Given this list of marker genes ZNF493, VDR, ZNF461, SETD1A, ZNF544, RAD51D, TFDP1, MYB, ZNF214, ELL, ZNF350, CHD4, RPS27A, SOX2, SUPT16H, H2AC14, LSM10, PTEN, MBD3, TFDP2, ZNF790, IWS1, THRB, PF4, RAD9A, ZNF671, JUN, MIR132, SIRT1, PRKAB2, CHEK1, ZIM3, POLR2I, RUNX3 (RUNX family transcription factor 3), ZNF79, BRD7, ZNF28, ZNF735, MAMLD1, TRIM63, ZNF33A, PHC1, ARID3A, PSMB4, USP2, ANAPC2, TBL1X, OPRK1, ZNF224, CNOT6, ZNF611, NR5A2, CBFB, PIP4K2C, G6PD, JUNB, SNAPC5, ZNF26, CREB1, H2BC14, ZNF200, H2BC15, ZNF627, MIR302B, GLI3, INTS10, MT-CO3, EHMT1, UBA52, BBC3, ZNF571, IHH, NR4A3, AGO4, LAMTOR5, PSMC5, GPX2, KMT2A, PHC2, H3C1 (H3 clustered histone 1, NCBI Gene Id 8350), SMURF1, H2BC11, SNRPD3, SSRP1, PRMT5, TFAP2B, NOTCH4, NR6A1, ZNF454, NOC2L, H2BC5, ZFP69B, MRE11, ZNF730, GTF2H5, MED8, ZNF610, ZNF684, COX7A1 (cytochrome c oxidase subunit 7A1), SOX9, ZNF253, RORB, H3C15 (H3 clustered histone 15), PHAX, PCK1, GATA3, ICE1, CSTF3, PPP2CA, ELL2, ZNF75D, GPS2, ZNF737, ZNF761, POU2F2, NR1D2, ZNF432, RRAGC, YWHAH, MED23, ELL3, ZNF551, MYBL2, ZNF519, SMAD6, SESN2, SMAD1, TEAD2, WDR5, CSF1R, ARID2, ZIM2, CCND3, NABP1, ZNF221, ZNF697, ZNF222 (NCBI Gene Id 7673), ZSCAN32, CR1, H2BC1, NCOR1, SOCS4, PML, NR2F6, ZNF470, PLK3, ZNF74, CTLA4, CSNK2A2, MECP2, SKIC8, EXO1, COX5B, LGALS3, RPRD1A (regulation of nuclear pre-mRNA domain containing 1A), WWOX, PCGF5, CDK2, ABL1, ZNF215, RARB, MLLT3, PSMB7, SUPT5H, H2AJ, SMAD4, TP53BP2, ARNT (aryl hydrocarbon receptor nuclear translocator), TNFRSF10C, MED26, MAF, ATAD2, HDAC2, TFAP2D, ZNF34, ZNF705G, CNOT10, ZNF620, MSTN (myostatin), H2BC12, ZNF506, ZNF441, ZKSCAN1, ZFP90, RBFOX3, CGA, ZNF705D, FANCI, NR3C1, ZNF772, SMARCA2, ZC3H8, MED4, HES1, TNRC6B, ZNF679, ZNF584, ZNF699, BMI1, CDK5R1, NEDD4L, ZNF124, TP53I3, PSMD11 (NCBI Gene Id 5717), PRKAB1, RFC5, TAF13, NPY (NCBI Gene Id 4852), PRKCQ, GSK3B, BTG1, YWHAG, ZNF354B, ZNF320, RHEB, RRM2, SMAD7, ZKSCAN8, RABGGTA, UBE2D1 (ubiquitin conjugating enzyme E2 D1), ZNF615, PMS2, DEK, PPP1R13L, INTS3, ANAPC15, ZNF445, MED24, NR1D1, POLR2D, INTS8, PSMB1, PRKACA, INTS2, SPP1, HUS1, APAF1, POLR2F, CAMK2A, SNW1, YEATS4, PSMC2 (NCBI Gene Id 5701), ZNF331, YWHAZ, HIGD1C (HIG1 hypoxia inducible domain family member 1C), TAF7, FIP1L1, FZR1, RPRD2, BIRC5, SKIL (SKI like proto-oncogene), ZNF135, LDB1, KMT2C, CDK8, ANAPC10, TP63, CNOT8 (NCBI Gene Id 9337), ZNF19, AR, SMARCC1, CNOT6L, NR3C2, JMY, DYRK2, TAF10, ZNF724, CNOT7, ZNF75CP, ITGA5, RBPJ, SNRPG, L3MBTL2, BDNF, SKI, SMYD2, ZNF517, ZIK1, PPP1R13B, PPARD, TWIST2, POLR2A, FOXO4, CTNNB1, TSC2, ZNF263, MDM4 (NCBI Gene Id 4194), USP9X, DNA2, TNRC6A (trinucleotide repeat containing adaptor 6A), LAMTOR1, ARNT2, IGFBP1, TNFRSF18, ZNF577, TAF15, MED25, TAF4, SUZ12, ZNF41, CCND2, ELF1, RET, SMARCE1, SOD2, GPI, ZFP28, CITED2, BMP2, TIGAR, ZNF479, RNMT, CBX3, ZNF703, MYC, PCGF6, LAMTOR4, HTT, IL2RA, SFN, FOXG1, GTF2B, RBL2, ESRRB, PSMD14, OPRM1, ZFP69, ZNF394, ZNF785 (NCBI Gene Id 146540), MIR378, CCNT1, RNF34, BANP, INTS14, ELOA2, ESRRA, CYCS, ZNF140, SIN3B, MIR675, ZNF714, RABGGTB, CCNH, UXT, PCGF2 (polycomb group ring finger 2), ZNF840P (NCBI Gene Id 140896), PRKAA2, FASLG, H2AC4, PRDX1, CDKN2B, ZNF92, PSMB5, ING5, ZNF606, RSPO3, ZNF791, TAF4B, MEAF6, PIP4P1, MDM2, ATP1B4, GRIN2A, GAMT, ZFP37 (ZFP37 zinc finger protein), SP1, PSMA7, ZNF589, SMARCC2, COL1A2, PSMD7, ZNF426, TOPBP1, TNFRSF10A, MAPK11, NCOR2, THBS1, ZNF713, BNIP3L, RARG, ZNF732, miR-224, INTS5, RPA3, NABP2, RUNX2, IL6, LMO1, TP53RK, TAF12, PSMB6, ZNF776, CSNK2A1, ELOC, ZNF416, TXN, ZFP30, TNKS1BP1, TJP1, INTS1, CDC7, DLL1 (NCBI Gene Id 28514), PSMA6, ZNF681, ZNF429, NFE2 (NCBI Gene Id 4778), NFKB1, ARID1A, TTC5, ZNF860, ZNF431, BAX, NELFE, ZNF721, GTF2E2, MAML3, GTF2A2, MIR24-1, CNOT3, NLRC4, ZNF773, STK11, KLF4, MIR18A, KRABD5, RPA2, ZNF664, CBX8, ZNF559, CDK6, EHMT2, ZNF740 (NCBI Gene Id 283337), PRDX2, ZNF197, ZNF471, SMARCA4, PRKAG2, ANAPC4 (anaphase promoting complex subunit 4), CCNB1, UBE2I, SGK1 (serum/glucocorticoid regulated kinase 1, NCBI Gene Id 6446), PGR, ZNF169, TAF1L, RRAGA, CDKN1A, TCEA1, ZNF317, ZNF266 (NCBI Gene Id 10781), BRPF1, NELFCD, TRPC3, SLC2A3, CDK13, DAXX, ZNF662, SMARCD3, ZNF677, NCBP1, H2AZ2, CCND1, ZNF225, AIFM2, CCNG2, ZNF17, PRMT1, RMI1, PPP2R1B, RORA, ANAPC5, TAF9, ZNF563 (NCBI Gene Id 147837), RARA, ING2, ZFPM1 (NCBI Gene Id 161884), CDC26, NOTCH1, RNU11, RNF2, ATR, ZNF333, BRCA1 (BRCA1 DNA repair associated), BMAL1 (basic helix-loop-helix ARNT like 1), CPSF1 (cleavage and polyadenylation specific factor 1), RB1, GATAD2A, TP73, MED7, ZNF446, SPI1, ZNF767P, PIP4K2B, PSMA3, ZNF480, ZNF433, ZNF311, TEAD3, ZNF670, LAMTOR2, DDIT4, ZNF442, NFYB, POLR2B, UBE2C, HEY2, ZNF43, MAPK1, ZNF667, ZNF558, ZKSCAN5, RNU4-1, ZNF675, BTG2, KRABD4, ZNF750, GTF2H1, SNAPC4 (small nuclear RNA activating complex polypeptide 4), MLH1, NOP2, DLX6, H2AC20, ZNF692, AXIN1, ZNF154, ZKSCAN4, LEO1, NR1H4, SMARCB1, KDM5B, SCO2, ACTL6B, TEAD1, ZNF223, PRKAG1, EED, POLR2L, ZNF595, HIPK1, CASP10, COX8A, ZNF136, ZNF586, CASP6, PSMA5, ZNF141, CPSF4, NPM1, AFF4, CCNE1, TP53, GAD1, ZNF562, GADD45A, H4C1, POLR2J, FOXP3, ZNF343, RXRB, ZNF705A, COX6B2, EAF2, TCF12, PTPN1, ZNF37A, CBX5, INTS4, KCNIP3, COX7B, SNAPC3, CITED1, MSH2, DLX5, H2BC17, ATXN3, ZNF561, ZNF213, ZNF668, NR2E1, GTF2F2, ZNF774, RBBP5, NELFB, DPY30, ZNF738, ZNF599, CAV1, NR5A1, MIR137, E2F1, IRAK1, RBFOX1, POMC, FOXO1, SLBP, ZNF689, KCTD15, ZNF804B, ITGA4, CTSL (cathepsin L), RYBP, PVALB, PPP2CB, H2AB1, NCBP2, PPARA, RPTOR, DDB2, ZNF500, RNU1-1, CSTF1, CCNE2, CDK12, STEAP3, ZNF565, RICTOR, HDAC1, MAML2, ZNF700, MED17, RNU4ATAC, NFYA, ZNF585B, RNU5A-1, HNF4A, ZNF180, RFC3, MGA, ZNF676, PABPN1, H2AC7, H2BC4, CPSF2, ZNF75A, AKT3 (NCBI Gene Id 26068), ZNF514, ITCH, PITX2, ZNF658B, ZNF138, ANAPC11, SERPINE1, RGCC, NR0B2, ZNF100, GATA2, POLR2C, ZNF324, ZNF23, PARP1, ZNF195, BID, TAF9B, PSMC6, SERPINB13, PSMA4, ZNF189, BRIP1, MTA2 (NCBI Gene Id 9219), TGIF1 (TGFB induced factor homeobox 1), INTS9, BCL2L14, PRMT6, ZNF302 (zinc finger protein 302), RXRG, ZNF554, ARID1B, TAF2, RAD9B, TAF5 (NCBI Gene Id 6877), ZNF688, PSMD8, ZNF212, TAF6, ZNF701, KRABD3, BRPF3, MYL9, GP1BA, GCK, ZNF546, VENTX, MED31, CCN2, ZNF227, ZNF248, KMT2D, UCMA, COL1A1, MAML1, MIR26A1, NR2F1, SUPT6H, COX4I2, SYT10, YY1, ZNF552, CDC27, CPSF7, ZNF264, BLK, NR2C2AP, H2BC26, PRDX5, MAPKAPK5, IL2, SIN3A, H2AC6 (H2A clustered histone 6), CSNK2B, HDAC7, TAL1, AGO3, YWHAQ, ZNF286A, CPAP, NR2C2, RBBP4, HAND2, ZFP2, ZNF418 (NCBI Gene Id 731194, zinc finger protein 418), KAT6A, THRA, ZNF573, G6PC1, WRN, SMAD3, FURIN, XPO1, ZNF33B, MMP13, MAX, KAT2B, CALM1, NAMPT, CAMK2D, ZNF770, ZNF486, SREBF1, LBR, RING1, ANAPC7, MIR26A2, ZNF746, TCF3, UBE2E1, RUNX1, TCF7L1 (NCBI Gene Id 83439), PRKCB, ZNF616, HDAC3, ZFP1, ZNF287, RRAGD, ZNF257, ZNF711, PMAIP1, GATA4, ZNF3, GRIA2, ZNF528, NR1I2, CEBPB (CCAAT enhancer binding protein beta), ZNF304, INTS6, TP53AIP1, MIR106A, TRIM28, CSTF2T, MAPK14, RELA, CARM1, POU4F1, MOBP, CPSF6, TAF3, ZNF226, HIVEP3, E2F8, ZNF101, ZNF496, CNOT1, ZNF99, ZNF282, SMARCD1, CSF2, BCL6, NR1H3, HDAC5, ZNF235, TNRC6C, CSTF2, CNOT9, RAD50, ZNF205, SYMPK, ZFP14, TGFA, ZNF430, TSC1, NELFA, RETN, ACTL6A, ZNF543, ZNF702P (zinc finger protein 702, pseudogene), VEGFA, COX4I1, ZNF12, TCF7L2, LAMTOR3, ZNF337, EPC1, USP7, HEY1, GATAD2B, NOTCH3, LEF1, ZNF555, PSMA1, CDKN2A, RAD17, NUAK1, PSMC4, STAT1, CDK9, RORC, TFAP2E, STUB1 (STIP1 homology and U-box containing protein 1), ZNF691, NR0B1, POLR2H, PPARG, NBN, ZNF211, COX7A2L, E2F4, AKT1 (NCBI Gene Id 207), ZNF300, ITGBL1, MTOR, ZNF77, ZNF256, SRRT, ZNF114, CRH, ZNF621, H2AC18, DDIT3, EAF1, PRELID3A, ZNF669, YAP1, ZNF585A, PRR5, TAF1, PIP4K2A, ZNF727, ZNF704, ZNF613 (zinc finger protein 613), ZNF680, NOTCH2, ZFHX3, FOXO6, MAPK3, TBX5, SRC, SUPT4H1, ZNF485, TP53INP1, ANAPC1, CHM, ZNF415, PSMD6 (proteasome 26S subunit, non-ATPase 6), NUDT21, PRKAG3, ZNF45, SEM1, RXRA, MDC1, ZNF710, ZNF764, ZNF717, CTR9 (CTR9 homolog, Paf1/RNA polymerase II complex component), GEM, OCLN, BGLAP, SESN3, GTF2H4, ZNF706, ZNF556, POLR2G, YES1, ZNF707, TGIF2, ZNF705EP, ZNF660, NFYC, ZNF208, POLR2E, ZNF483, H2BC21, SMAD2, MSX2, HNF4G, ZNF439, ZNF112, CDKN1B, PBRM1, JAG1, HDAC10, MIR215, SESN1, ERCC3, ABCA6, ELF2, ZNF875, GTF2H3, ASH2L, LMO2, E2F5, ZNF777, ZNF557, MED27, CITED4, TEAD4, FAS, SLC38A9, ZNF14, PSMC1 (proteasome 26S subunit, ATPase 1), RFC4, SNAPC1, ZNF570, MNAT1, NRBF2, ATRIP, NR4A2, MIR20A, ZNF726, ZNF658, ZNF20, ZNF230, RNF111 (NCBI Gene Id 54778), CAMK4, ZNF775, SMURF2, PSMD1, TRIM33, POU4F2, ZNF607, SETD9, PSMB2, ZNF354C, GSR, NR2C1 (nuclear receptor subfamily 2 group C member 1), CDC23, ZNF718, ZNF597, RTF1, MLLT1, MED6, ZNF792, ZNF799, RNU12, CTSV, PRELID1, LIFR, HDAC9, IFNG, COX6A2, PPM1D, ZNF133, TFAP2C, ELOB, HSPD1, CCNK, ZNF549, TNFRSF10B, PINK1, ZNF155, ZKSCAN3, ZNF420, HDAC8, MOV10, ZNF569, ZNF492, PLAGL1, NRBP1, PLXNA4, ICE2, CDC25C, PSMD2, YAF2, KMT5A, TRIAP1, ZNF443, ZNF619, FOS, UBB, UBE2D3, PPP2R5C, ZNF678, PHF20, RNU2-1, ANAPC16, RPAP2, ZNF583, CCNA2, ZNF398, ESR2, KAT2A, ZNF665, RRM2B, PIDD1, COX5A, CRADD, MED1, RFFL, ZNF440, H2BC12L, RHNO1, CNOT4, GTF2H2, H2BC3, ZNF550, ZNF709, ZNF157 (zinc finger protein 157), GTF2A1, MIR27A, CAT, PRDM7, ZNF202, HDAC11, ITGAL, RFC2, ZNF596, ZNF2, ZNF749 (NCBI Gene Id 388567), COX7C, CDC16, E2F7, TCF7, ZNF484, DGCR8, SP7, CPSF3, ZNF10, HDAC6, CDC73, MAGED1, CLP1, HIPK2, MED10, ZNF747, EZH2, ZNF839, ZNF382, INTS7, TGFB1, ZNF268, POLR2K, SST, CNOT11, GATA1, AUTS2, TWIST1, PDPK1, ZNF626, INTS13, ZNF716, CBX2, POU2F1, ZNF417, MED16, ZNF529, PPP2R1A, UBC, PAPOLA, ZNF234, ZNF736, RBBP8, PAF1, AKT2, REST, COX7A2, INTS12, FBXO32, ZNF233, ADRM1, AURKA, IL3, IGFBP3, ZNF649, TAF11, PCNA, E2F6, LSM11, TNFRSF10D, ZNF729, NR1I3, SOCS3, TOP3A, PTPN11, COX6C, TXNRD1, GLS2, FANCD2, ZNF143, ELOA, BLM, ZNF793, AURKB, H2AX, PSMD3, MIR24-2, YWHAB, GLS, ZNF324B, TBP, IQSEC3, ZNF468, FKBP5, PSMB3, RPRD1B, ZNF696, TMEM219, ZNF334, ZNF560, ZNF25, KIT (KIT proto-oncogene, receptor tyrosine kinase), RNGTT (RNA guanylyltransferase and 5'-phosphatase), ZNF624, BRD1, WDR33, MAPKAP1, SKP2, H2BC13, MED13, ZNF160, ZNF540, ZNF30, SETD1B, UBE2S, ZNF530, SATB2, CLDN5, GPRIN1, ZNF175, ZNF267, SRF, NFATC2, ZNF641, RBM14, ZNF354A, ZNF436, GRIN2B, ZNF771, RBX1, FANCC, PTPN4, MED15, TFAP2A, SSU72, KAT5, PAX5, ATF2, YWHAE, SNRPB, PIN1, CCNG1, KCTD6, ZNF547, MED20, TBL1XR1, MED14, ITGA2B, PHC3, ZNF425, COX8C, ZNF383, ZNF285, EGFR, ZNF419 (zinc finger protein 419), CNOT2, ZNF567, ZNF18 (zinc finger protein 18), RBBP7, COXFA4, ESRRG, ZNF614, SKP1, RAD51, PRDM1, RAD1, CHEK2, CASP2, BRD2, ERCC2, MED12, SIRT3, CDK1, ZNF726P1, KRAS, MT-CO1, CDK7, ZSCAN25, CAMK2G, ESR1, CUL1, CCNC, COX6A1, ZNF582, CAMK2B, NR2E3, APOE, ZNF347, CBX4, RBL1, GTF2F1, ZNF548, ZNF273, INTS11, CTSK, WWP1, NR1H2, CASP1, CGB3 (chorionic gonadotropin subunit beta 3), ZNF625, YBX1, CHD3, RMI2, ZKSCAN7, PSMD12, ZNF564, COX6B1, PLK2, KCTD1, ZNF708, ZNF782, CDK5, CCNA1, NDRG1, GLI2, CCNT2, AGO1, EP300, ZNF786, SNAPC2, PPARGC1A, MET, CREBBP, AGRP, ZNF521, KMT2B, ZNF778, PPM1A, GPAM, PERP, CDK4, BCL2L11, ZNF566, PCF11, ZNF605, ZNF682, ZNF568, PCBP4, TPX2, SMARCD2, H2BC9, ZNF184, GTF2E1, CBX6, MT-CO2, MED30, ERBB2, GAD2, MEN1, ZNF490, ZNF655, PSMC3, SNRPF, NKX2-5, WWTR1, MAP2K6, NKX3-2, TXNIP, FOXO3, RRAGB, PSMD13, TAF8, NR4A1 (nuclear receptor subfamily 4 group A member 1, NCBI Gene Id 93352), TAF7L, ZNF473, ZNF274 (NCBI Gene Id 51732), HDAC4, ATM, PSMA2, ZNF385A, SUMO1, SCMH1, BARD1 (NCBI Gene Id 580), AGO2, ZNF600, NPPA, H3-3A, ZNF254, PRKAA1, MIR17, ZNF71, ZNF460, MLST8, ZNF587, ZNF250, NPAS4, CTDP1, PPARGC1B, ZNF510, H19, MEF2C (NCBI Gene Id 4208), ZNF70, INS, SNRPE, L3MBTL1, RPA1, here is a description of the gene set: part of: Gene expression (Transcription) Reactome Pathway: RNA Polymerase II Transcription RNA polymerase II (Pol II) is the central enzyme that catalyses DNA- directed mRNA synthesis during the transcription of protein-coding genes. Pol II consists of a 10-subunit catalytic core, which alone is capable of elongating the RNA transcript, and a complex of two subunits, Rpb4/7, that is required for transcription initiation. <BR> The transcription cycle is divided in three major phases: initiation, elongation, and termination. Transcription initiation include promoter DNA binding, DNA melting, and initial synthesis of short RNA transcripts. The transition from initiation to elongation, is referred to as promoter escape and leads to a stable elongation complex that is characterized by an open DNA region or transcription bubble. The bubble contains the DNA-RNA hybrid, a heteroduplex of eight to nine base pairs. The growing 3-end of the RNA is engaged with the polymerase complex active site. Ultimately transcription terminates and Pol II dissocitates from the template. species: Homo sapiens